Given this list of marker genes DENND5A, IRX5, PAX3, IRX2, CBS, RASSF2, CCDC140, here is a description of the gene set: Genes down-regulated in pilocytic astrocytoma (PA) from supratentorial regions compared to the infratentorial PA tumors. from publication Sharma MK, Mansur DB, Reifenberger G, Perry A, Leonard JR, Aldape KD, Albin MG, Emnett RJ, Loeser S, Watson MA, Nagarajan R, Gutmann DH (PMID 17283119) Human Gene Set: SHARMA_PILOCYTIC_ASTROCYTOMA_LOCATION_DN Pilocytic astrocytomas (PAs) are the most common glioma in children. Whereas many PAs are slow-growing or clinically indolent, others exhibit more aggressive features with tumor recurrence and death. To identify genetic signatures that might predict PA clinical behavior, we did gene expression profiling on 41 primary PAs arising sporadically and in patients with neurofibromatosis type 1 (NF1). Whereas no expression signature was found that could discriminate clinically aggressive or recurrent tumors from more indolent cases, PAs arising in patients with NF1 did exhibit a unique gene expression pattern. In addition, we identified a gene expression signature that stratified PAs by location (supratentorial versus infratentorial). Lastly, we also identified a gene expression pattern common to PAs and normal mouse astrocytes and neural stem cells from these distinct brain regions as well as a gene expression pattern shared between PAs and another human glial tumor (ependymoma) arising supratentorially compared with those originating in the posterior fossa. These results suggest that glial tumors share an intrinsic, lineage-specific molecular signature that reflects the brain region in which their nonmalignant predecessors originated. species: Homo sapiens